Given this list of marker genes PREX2, C11orf54, RCC2, KLC1, UBE2R2, SGCZ, FBXL5, ELFN1, MITD1, AP3M1, ZNF551, RNF149, SKAP2, ZNF81, MICB (MHC class I polypeptide-related sequence B), TLL1, ATAD2B (NCBI Gene Id 54454), KIF21A, RALGDS, HSD17B4, GTPBP8, STON2, CDH2, CALML4, TMCO1, PRKD3, MAML3, ABHD18, CCPG1, MARF1, GRM3, BNIP3, STK17A, ZNF680, GPR65, DUSP1, EXOSC3, PGAM5, KIAA1614, PXDC1, NR3C1, C11orf21, NXPE4, FEM1C, MOSMO, NRBP1, SPRY4, DBF4, here is a description of the gene set: from publication Chen Y, Wang X (PMID 31504780) Human Gene Set: MIR411_5P Genes predicted to be targets of miRBase v22 microRNA hsa-miR-411-5p in miRDB v6.0 with MirTarget v4 prediction scores > 80 (high confidence targets). studied in species Homo sapiens